Given this list of marker genes SLC34A2, here is a description of the gene set: studied in species Homo sapiens Reactome Pathway: Defective SLC34A2 causes pulmonary alveolar microlithiasis (PALM) part of: SLC transporter disorders SLC34A1 and 2 encode Na+/Pi cotransporters, which cotransport divalent phosphate (PO4(2-), Pi) with 3 Na+ ions. SLC34A2 is abundantly expressed in lung and to a lesser extent in tissues of epithelial origin including small intestine, pancreas, prostate, and kidney. Defects in SLC34A2 are a cause of pulmonary alveolar microlithiasis (PALM; MIM:265100), a rare disease characterised by the deposition of calcium phosphate microliths throughout the lungs. The disease follows a long-term progressive course, resulting in a slow deterioration of lung function.